The following is a description of a gene set: Human Gene Set: HP_DECREASED_MITOGEN_INDUCED_T_CELL_PROLIFERATION studied in species Homo sapiens Abnormal decrease of T cell proliferation in response to mitogenic stimuli. This is commonly measured through intracellular expression of Ki67, decreasing surface expression of carboxyfluorescein diacetate (CFSE), or 3H-thymidine incorporation. Length of incubation, specific stimulus and strength of stimulation may vary between laboratories. Decreased mitogen-induced T-cell proliferation, and this is the list of marker genes: RFXAP, STAT1, SYK, EXTL3, RASGRP1, MALT1, PIK3CD, KNSTRN, CD3D, RFX5, IL7R, RAG1, IL2RG, SLF2, PSMB10, RAC2, RFXANK, FOXN1, JAK3, IL2RA, CD3E, IKBKB, TNFRSF9, ZAP70, MCM10, CIITA, MGAT2, CD247, CD27, RAG2, PNP